The following is a description of a gene set: studied in species Homo sapiens Interactions of Rev with host cellular proteins Human Gene Set: REACTOME_INTERACTIONS_OF_REV_WITH_HOST_CELLULAR_PROTEINS, and this is the list of marker genes: NUP50, NUP85, SEH1L, NPM1, XPO1, AAAS, NUP43, NUP58, NUP88, POM121 (NCBI Gene Id 9883), NUP210, NUP54, NUP107, POM121C, RANBP2, NUP153, RCC1, RANGAP1, NUP214, KPNB1, RANBP1, NUP37, NUP133, TPR, NUP98 (NCBI Gene Id 51457), RAE1, NDC1, NUP62, NUP35, NUP205, SEC13, NUP155, RAN, NUP160, NUP188 (NCBI Gene Id 23511), NUP42, NUP93